Given this list of marker genes TBC1D13, EEF1E1, FGF18, ELK3, TCERG1, FAM149B1, DPF2, NCAPG2, INMT, ACTR3, HGSNAT, MDM2, SYS1, RNF34, IFT22, TJP1, MATR3, MRPS22, SGCB, IMPDH1, RAB5IF, SLC39A9, TLK2, CHRM4, ENG, RAD9A, EPB42, SLC1A2, EMC7, UTS2R, ENPP3, HDAC9, HTR2B, ST7, C1QC, NFAM1, AIF1 (allograft inflammatory factor 1), PARP8, ANXA1, DNAAF5, WDR77, KDR, DUSP15, CRELD2, UBE2I, TAP1, STK24, RRAS2, PSME1, VPS54, TRIM21, SOCS4, RAB22A, NDRG1, AOC1, IL18BP, MUC1 (NCBI Gene Id 4582), PALS2, MPDU1, PSMA5, SAP30, HLA-B, P2RY14 (purinergic receptor P2Y14), DHPS, TAPBPL, PLBD2, ERBB3, RIOK3, COL4A4, HEYL, CCR5, SNX2, PLPP1, MRPL47, CRP, ANPEP, DHX40, UBR2, TPST1, HNRNPDL, CHMP4B, F7, BATF2, COX18, PPP2R3C, TEN1, SMS, PSEN1, TREX1, SPTLC1, ARHGAP10, RNF114, IFI35, FNBP4, UBE2L6, CFB, RABL3, SRD5A3, CDK8, DCK, DBT, BCKDHB, PDE6D, RANBP9, KAT6A, MTMR2, BLNK, CAMLG, MORF4L1, CBX6, ATG3, SLC7A8, MAP4K3, FNDC3A, SP110, TMA16, CCL4, SLC13A3, RBM3, STIP1, TMEM143, USP24, PSMG3, FAM3C (NCBI Gene Id 10447), SMNDC1, PEX5, MEMO1, PTPN14, FTH1, RBM17, SOX18, STAMBP, CDS2, TUBA1A, ATP10A, RHOC, CD274, ZC3H12C, MTARC2, RBM10, CZIB, AZIN1, COA5, SERP1, PLPP3, DUSP2, MITD1, PCSK7, COL1A2, RRN3, RGL1 (ral guanine nucleotide dissociation stimulator like 1), PRM2, PPP4R2, CFAP20, RNF135, APAF1, ST7L, TOR3A, DDX60, USB1, GBP6, TMEM129, ALCAM, ZNF426, PWP2, REPIN1, HAX1, NMT2, RAB6A, TUBB2A, RIOX2, CCNJ, ATP2B2, F2, CASP7, ANTXR2, PSME2, POMT1, LGALS3BP, SEC11A, CCRL2, PACC1, NT5C3A, DNM2, CCL13, SEC14L2, NCF4, GRSF1, CD2AP, PSMB6, PDLIM1, MRPS2 (NCBI Gene Id 64972), OCIAD1, GBP7, CYP39A1, NCSTN, KLF3, PDIA6, SMN1, CYFIP2, here is a description of the gene set: from publication Amit I, Garber M, Chevrier N, Leite AP, Donner Y, Eisenhaure T, Guttman M, Grenier JK, Li W, Zuk O, Schubert LA, Birditt B, Shay T, Goren A, Zhang X, Smith Z, Deering R, McDonald RC, Cabili M, Bernstein BE, Rinn JL, Meissner A, Root DE, Hacohen N, Regev A (PMID 19729616) species: Homo sapiens Human Gene Set: GSE17721_PAM3CSK4_VS_GADIQUIMOD_24H_BMDC_DN Genes down-regulated in comparison of dendritic cells (DC) stimulated with Pam3Csk4 (TLR1/2 agonist) at 24 h versus DC cells stimulated with Gardiquimod (TLR7 agonist) at 24 h. mouse primary BMDCs were stimulated with tlr ligands and gene expression changes were profiled on Affymetrix arrays